Given this list of marker genes Smad2, Smad3, Smurf1, Axin1, Acvr1b, Fkbp1a, Smad4, Smad5, Smad9, Tgfb1i1, Axin2, Smad1, Smad7, Smad6, Ctnnb1, Tgfbr1, here is a description of the gene set: Binding to an inhibitory SMAD signaling protein. studied in species Mus musculus Mouse Gene Set: GOMF_I_SMAD_BINDING